The following is a description of a gene set: Any process that modulates the frequency, rate or extent of blood vessel branching. studied in species Homo sapiens Human Gene Set: GOBP_REGULATION_OF_BLOOD_VESSEL_BRANCHING, and this is the list of marker genes: FGF2, CTNNB1, SIRT6, CTNND1, MDK, ABL1, FKBPL, VEGFA